The following is a description of a gene set: species: Mus musculus Fatty acid omega-oxidation Mouse Gene Set: WP_FATTY_ACID_OMEGAOXIDATION, and this is the list of marker genes: Adh7, Cyp2e1 (cytochrome P450, family 2, subfamily e, polypeptide 1), Adh4, Aldh1a1, Adh1, Cyp1a1, Aldh2, Cyp1a2